Given this list of marker genes TSC2, ABCG8, SLC37A4, KRAS, ECM1, GHR (growth hormone receptor), PCSK9, PDGFB, HLA-B, LMO1, IL12A-AS1, GLS, ABCA1, PDE11A, IL12A (interleukin 12A), TTPA, OCRL, LTV1 (NCBI Gene Id 84946), RAF1, PTPN6, MYSM1, CCR1, UBAC2, MMEL1, CYP27A1, PIK3CA, APOA2, FBN1, SEC23B, IARS2, ZEB2, COL3A1, TNFRSF11B, PHOX2B (NCBI Gene Id 8929), PORCN, TLR4 (NCBI Gene Id 7099), C4A, GLMN, B2M, SDHB, IFNGR1, APC, TEK, SDHD, TNFSF15, HLA-DRB1, HACE1, KIT, MEFV, IDH1, DDIT3, CYLD, PTPN11, HMGA2, INSR, GJB2, AKT1, GJB6, ABCC6, FERMT3, ASAH1, ATP2A2, MDM2, ERAP1, BRAF, LPL, BCL2, IDH2, LEMD3, ACVR1, STAT3, POMP, ALK, ANTXR2, PTEN, FGFR1, POU2AF1, COL7A1, GLA, BTNL2, MYCN, LDLR, NAGA, PTH1R, IL23R, STAT4, PPP1R17, FUS, FAS, APOB, KLRC4, SOX5, TSC1, LIN28B, IRF5, DACT1, CDK4, TNFRSF11A, COL5A2, ENPP1, APOE, FGFR2, NRAS, IFNG, MMP2, SPIB, IL12RB1, LSS, TNPO3, APOA1, COL1A1, G6PC1, SPRED1, MMP14, KIF1B, KLLN, IL10, KIF11, NOTCH3, SDHC, CTNNB1, COL5A1, GNAS, EXTL3, PDGFRB, BCL6, USF3, SALL1, PRKAR1A, EPHX2, here is a description of the gene set: Morphologically similar to a papule, but greater than either 10mm in both width and depth, and most frequently centered in the dermis or subcutaneous fat. Human Gene Set: HP_SKIN_NODULE studied in species Homo sapiens Skin nodule